The following is a description of a gene set: Any process that modulates the frequency, rate or extent of granulocyte differentiation. Human Gene Set: GOBP_REGULATION_OF_GRANULOCYTE_DIFFERENTIATION species: Homo sapiens, and this is the list of marker genes: EVI2B, HCLS1, C1QC, ADIPOQ (adiponectin, C1Q and collagen domain containing), TRIB1, ZBTB46, TESC, CUL4A, RARA, RUNX1, LEF1, HAX1, CEACAM1, IL5, MIR486-1, INPP5D, PRDM16 (NCBI Gene Id 647868)